Given this list of marker genes RPS7, FBXO5, CDKN2A, ARHGAP5-AS1, RPS15, RPL23, LIMK1, HTRA2, RPL37, BAG5, RPS20, RPL5, RPL11, here is a description of the gene set: Binds to and stops, prevents or reduces the activity of a ubiquitin ligase. Human Gene Set: GOMF_UBIQUITIN_LIGASE_INHIBITOR_ACTIVITY studied in species Homo sapiens